Given this list of marker genes Pten, Men1, Ret, Ccdc80, Nbn, here is a description of the gene set: Mouse Gene Set: MP_INCREASED_THYROID_ADENOMA_INCIDENCE Mouse genes annotated to increased thyroid adenoma incidence (MP:0003496) retrieved from the Mouse Genome Informatics database via MouseMine from publication Motenko H, Neuhauser SB, O'Keefe M, Richardson JE (PMID 26092688) studied in species Mus musculus